The following is a description of a gene set: electronically inferred by orthology from the curated human pathway species: Mus musculus Reactome Pathway: Regulation of ornithine decarboxylase (ODC) part of: Metabolism of polyamines This event has been computationally inferred from an event that has been demonstrated in another species.<p>The inference is based on the homology mapping from PANTHER. Briefly, reactions for which all involved PhysicalEntities (in input, output and catalyst) have a mapped orthologue/paralogue (for complexes at least 75% of components must have a mapping) are inferred to the other species., and this is the list of marker genes: Odc1, Psma6, Psmc6, Psmc1, Psmd12, Oaz1, Psmc4, Psmc3, Psmc5, Psma4, Psmb6, Psmb4 (proteasome (prosome, macropain) subunit, beta type 4), Psmb7, Psma1, Psmd1, Psma2, Psmd7, Psmb5, Oaz3, Psmd6, Nqo1, Oaz2, Psmc2, Psma7, Psmd13, Psma5, Psma3